The following is a description of a gene set: Aplasia involving forearm bones Human Gene Set: HP_APLASIA_INVOLVING_FOREARM_BONES studied in species Homo sapiens, and this is the list of marker genes: SALL4, XRCC2, FANCD2, FLNB (filamin B), TBX3, DONSON, ZIC3, RECQL4, FGFR2, LMBR1, CHD7, TRIO, WNT7A, RPL26 (NCBI Gene Id 6154), RBM8A, FANCL, GLI3, FANCI, ESCO2, RIPK4, FANCA, FANCC, FANCB, TBX5, SF3B4, MAFB, FANCE, CHN1